Given this list of marker genes Ift57, Cd109, Eppk1, Ift74, Snai2, Nfatc1, Zeb1, Intu, Ovol1, Klf9, Vdr, Cask, Ift122, Efnb2, Ptch1, Slurp1, Ift80, Sfn, Ptprk, Ift172, Ctsl, Kdf1, Ift52, Med1, Ift88, Irf6, Fgfr2, here is a description of the gene set: Mouse Gene Set: GOBP_NEGATIVE_REGULATION_OF_KERATINOCYTE_PROLIFERATION Any process that decreases the rate, frequency or extent of keratinocyte proliferation. Keratinocyte proliferation is the multiplication or reproduction of keratinocytes, resulting in the expansion of a cell population. species: Mus musculus